Given this list of marker genes ALDH6A1, PHYH (phytanoyl-CoA 2-hydroxylase), SC5D, HSD3B7, OXCT1, HLCS, CHST3, IVD, GK, GNS, LIPT2, IBA57 (iron-sulfur cluster assembly factor IBA57), ACAT1, PCK1, OCRL, AMACR, HADHA, MLYCD, BCKDHA, NAGA, MCCC1, PEX7, GNPAT, PLOD1, ASPA, HMGCL, CBS, AGPS, SPR, here is a description of the gene set: Concentration or activity of an enzyme is above or below the limits of normal in cultured fibroblasts. Fibroblasts are easy to grow in culture and are the main cell type involved in producing extracellular matrix. They are used as a convenient model system for measuring enzyme activity for enzymes that are not expressed in blood cells. Usually, the test is done in fibroblasts for convenience rather than for the investigation of a pathophysiology specific to fibroblasts. Human Gene Set: HP_ABNORMAL_ENZYME_ACTIVITY_IN_CULTURED_FIBROBLASTS species: Homo sapiens Abnormal enzyme activity in cultured fibroblasts